Given this list of marker genes ALAD, CPOX, ALAS2, ABCB7, PPOX, UROS, GATA1, CLPX, here is a description of the gene set: Concentration of porphyrins or of a specific porphryin above the upper limit of normal. The most commonly tested circulating porphyrins are coproporphyrin, protoporphyrin, and uroporphyrin. Normally protoporphyrin is present in the highest concentration. species: Homo sapiens Elevated circulating porphyrin concentration Human Gene Set: HP_ELEVATED_CIRCULATING_PORPHYRIN_CONCENTRATION